The following is a description of a gene set: Decreased fetal activity associated with multiple joint contractures, facial anomalies and pulmonary hypoplasia. Ultrasound examination may reveal polyhydramnios, ankylosis, scalp edema, and decreased chest movements (reflecting pulmonary hypoplasia). species: Homo sapiens Human Gene Set: HP_FETAL_AKINESIA_SEQUENCE Fetal akinesia sequence, and this is the list of marker genes: MYOD1, KIF21A (kinesin family member 21A), DOK7, MAGEL2, KLHL41, NEB, ZC4H2, MUSK, KBTBD13, TUBA1A, PHGDH, CNTNAP1, TPM2, RAPSN (NCBI Gene Id 85713), MYPN, ACTA1, ATP1A2, CHRNA1, RYR1, KIF5C, TPM3, TRPV4, KLHL40, LGI4, GLE1, CHRND, SLC18A3, CHRNG, NUP88, NEK9, PIGS, DPAGT1, CNTN1